Given this list of marker genes TRIM27, SP100, TRIM11, LARP7, ZFP36, RSF1, MDFIC, TRIM62, TRIM31, UBP1, DHX9, IFITM3, MID2, HEXIM1, TRIM8, TARBP2, TRIM13, TRIM21, TRIM14, TRIM32, here is a description of the gene set: Human Gene Set: GOBP_REGULATION_OF_VIRAL_TRANSCRIPTION species: Homo sapiens Any process that modulates the frequency, rate or extent of the transcription of the viral genome.